Given this list of marker genes ALK, here is a description of the gene set: Reactome Pathway: crizotinib-resistant ALK mutants Crizotinib is a type I tyrosine kinase inhibitor that is approved for treatment of ALK-positive non-small cell lung cancer. Crizotinib is also effective against ALCL and IMTs. Development of resistance to crizotinib is not uncommon, however, with patients acquiring secondary mutations or amplifications of the ALK gene that limit the effectiveness of the drug. This pathway describes ALK mutants that are resistant to crizotinib-mediated inhibition. part of: Drug resistance of ALK mutants species: Homo sapiens